The following is a description of a gene set: studied in species Homo sapiens Human Gene Set: SA_G2_AND_M_PHASES Cdc25 activates the cdc2/cyclin B complex to induce the G2/M transition., and this is the list of marker genes: CHEK1, CDC25A, CDC25B, WEE1, CDK1, CDK7, CDKN1A, NEK1